The following is a description of a gene set: The series of molecular signals initiated by binding of a ligand to the tyrosine kinase receptor ERBB4, followed by ligand-induced homodimerization of ERBB4 and transmission of the signal into the cell by the homodimeric ERBB4 complex. The pathway ends with regulation of a downstream cellular process, e.g. transcription. studied in species Mus musculus Mouse Gene Set: GOBP_ERBB4_ERBB4_SIGNALING_PATHWAY, and this is the list of marker genes: Ereg, Nrg4, Btc, Nrg1, Nrg2, Nrg3, Erbb4